Given this list of marker genes RHNO1, RRM1, RRM2B, SOX15, MED1, here is a description of the gene set: species: Homo sapiens A cell cycle process that activates or increases the rate or extent of the transition from the G0 quiescent state to the G1 phase. Human Gene Set: GOBP_POSITIVE_REGULATION_OF_G0_TO_G1_TRANSITION